The following is a description of a gene set: from publication Nakaya HI, Wrammert J, Lee EK, Racioppi L, Marie-Kunze S, Haining WN, Means AR, Kasturi SP, Khan N, Li GM, McCausland M, Kanchan V, Kokko KE, Li S, Elbein R, Mehta AK, Aderem A, Subbarao K, Ahmed R, Pulendran B (PMID 21743478) species: Homo sapiens Systems vaccinology has emerged as an interdisciplinary field that combines systems wide measurements and network and predictive modeling applied to vaccinology. Here we used the systems vaccinology approach to study the molecular mechanisms underlying th Genes up-regulated in comparison of peripheral blood mononuclear cells (PBMC) from TIV influenza vaccinee at day 3 post-vaccination versus those at day 7 post-vaccination. Human Gene Set: GSE29617_DAY3_VS_DAY7_TIV_FLU_VACCINE_PBMC_2008_UP, and this is the list of marker genes: PDE4A, ADGRE2, PAPSS2, GPBAR1, SAMD4A, EPS8 (EGFR pathway substrate 8, signaling adaptor), SERPINB2, MS4A7, ARF6, CST3, BTC, EEIG2, GBP2, GRB14, DCD, LIPG, BRINP1, SAMHD1, SKA3, NAAA, LITAF, ZNF628, FZD1, TNFRSF19, CHODL, TTC23L, NR4A3, RHOB, SAMD5, UMODL1-AS1, DZIP1L (DAZ interacting zinc finger protein 1 like), AMPD2, FSCN2, STOM (stomatin), COL4A5, SH3BGRL, S100A4, CSF1R, KLRD1, ATF3, KRTAP2-4, DHX58, CTBP2, FNIP2, ARMC12, CDK2AP1, C1orf162, NPTN, TNFAIP6, MMP24, CHMP1B, ANKRD22, CDKN1C, TNFSF13B, CORO1B, VCL, ARPC2, CACUL1, MAPKAPK3, FIBP, VN1R5, EHMT1, SNX18, MT1G, AGPS, TRPS1, LAMP1, INIP, HTR1B, COMMD8, HIGD1A, CMTM6, AADAC, REEP5, THRSP, RO60, CAPNS1, FMNL2, MYOF, DCDC1, MT1X, CREBRF, PSAP, CALCOCO2, RAB36, PLEK, STX11, HUS1B, FERMT3, SRGAP2C, VDAC1, IPMK, LST1, VNN3P, CRYBA1, STK3, ZFAND5, MFSD5, TRIM49, TCF7L2, JAZF1-AS1 (NCBI Gene Id 100128081), ZNF618, ZNF684, ADGRE1, RAC1, RXFP1, GAP43, PRSS12, TENT5A, IQSEC3, MARK1, MOB1A, ASB8, RAB11A, PDZRN4, CAMK1, MTSS1, TUBB1, ELF4, TWSG1, ALDH3B1, NLRP8, RGS18, NPC2, TXNRD1, POLR2G, EGF, CD300A, EML5, ASAH1, SLC7A3, ARL6IP5, MIR924HG, ENSG00000245651, GDI2, RHOG, DUSP4, CTNNA2, SLC22A5, GBP1, CCDC148-AS1, PRKCZ-AS1, MBD2, IFIT2, FBP1, SPATA6, INSL6, TPI1, RAP1B, GCH1, LHFPL3-AS1, PSMA4, IL6, KIR2DL4, SEZ6L, PTPN18, RFC3, PIK3AP1, SCEL, MAP3K1, TTC29, CACNA1S, CXCL10, CALM2, CTSC, MAPT, FEZ1 (fasciculation and elongation protein zeta 1), LGALS9, NTRK2, AIF1, VAMP5, DSCR10, ZNF703, CTSL, GK, SUCNR1, CLCA1, SLC31A2, LEPROT, EGR2, BID, CSK, PLOD2, SECTM1, E2F3, NOTCH2, GLUD1, SSTR5-AS1, ZBTB47